The following is a description of a gene set: species: Homo sapiens Human Gene Set: GOMF_PROTEIN_PRENYLTRANSFERASE_ACTIVITY Catalysis of the covalent addition of an isoprenoid group such as a farnesyl or geranylgeranyl group via thioether linkages to a cysteine residue in a protein., and this is the list of marker genes: PGGT1B, PTAR1, FNTB, FNTA, RABGGTB (NCBI Gene Id 5876), CHM, RABGGTA